Given this list of marker genes XYLB, NOB1, FXYD5, ZIC3, PUS1, MAFG, RASSF3, HSF2BP (NCBI Gene Id 11077), RNASEK, GBP2, NOP10, LCP1, RPL31, BCKDHB, OSTF1, RPL15, FOXO1, TPST2, POLDIP2, PRDX3, ARHGAP25, SPMIP10, CCR4, NME2 (NME/NM23 nucleoside diphosphate kinase 2), MRPL46, PSMG1, IGFBP1, CCHCR1, EIF3H, PDE3B (NCBI Gene Id 5140), GIPC1, CRLF2, C19orf12, STT3B (NCBI Gene Id 201595), CYTH4, PCCA, RPL10, IPCEF1, MRPS18B, ING5, IKZF2, MRPL23, SMAP2, NICN1, ALAS1, SELENOS, DYRK2, RPS26, AFDN, MFNG, CYP20A1, GIMAP3P, COPS9, PPP1R7, BRI3BP, RPL12, LGMN, TECR, IL10RB, ADGRB1, XPOT, ALDOA, NOL12, MRPS9, HADH, HIGD2A, TMEM25, EEF1D, ITM2B, BAIAP3, COQ2, EIF3E, ABHD14A, SNAP47 (NCBI Gene Id 116841), FBXO31, ATP5MJ (NCBI Gene Id 9556), PSMB3, EIF4B, B2M, STING1, MMP3, TH, DHRS1, MTAP, MYO1G, HEXB, PIGX, WDR59, IL7R, SRPX, MRRF, FBXL8, RFC2, PSMB1, OXCT1, GPR65, NXPH1, N4BP2L1, SHISA5, MTURN, TRMT1, PYHIN1, ALDH2, RAPGEF4, ZFP36L1, IPO4, S100A10, TTC9B, PSMA7, CD226, PRKAA1, TNFAIP8L2, VAMP8, CCNG1, GID4, TAGLN2, GSTP1, CLIC1, COMMD5, ISCA2, MLEC, SUCLG2, CD7, SLFN5, COX7A2L, PSME2, LTB, IFT22, ISYNA1, NPC2, EYA2, IL12RB2, MRPL48, RPL29, SNX5, MFGE8, NUP210L, PSMB9, POLR2F, SLC25A5, DDX51, TMEM185A, LEPROTL1, MED11, SBSN, PCBD2, ANKRD13B, TBC1D32, CNPPD1, RAC3, SMAD1, LY9, RIPPLY3, ASCL4, C19orf38, IFI35, KCNA2, ATP1B3, OSM, GLRX5, POLRMT, CELA1, CTPS2, PVT1, RRP15, FUT11 (fucosyltransferase 11), UTRN, CD53, RPS6KA1, AGFG1, here is a description of the gene set: BACKGROUND: Dendritic cells (DC) play a central role in primary immune responses and become potent stimulators of the adaptive immune response after undergoing the critical process of maturation. Understanding the dynamics of DC maturation would provide key insights into this important process. Time course microarray experiments can provide unique insights into DC maturation dynamics. Replicate experiments are necessary to address the issues of experimental and biological variability. Statistical methods and averaging are often used to identify significant signals. Here a novel strategy for filtering of replicate time course microarray data, which identifies consistent signals between the replicates, is presented and applied to a DC time course microarray experiment. RESULTS: The temporal dynamics of DC maturation were studied by stimulating DC with poly(I:C) and following gene expression at 5 time points from 1 to 24 hours. The novel filtering strategy uses standard statistical and fold change techniques, along with the consistency of replicate temporal profiles, to identify those differentially expressed genes that were consistent in two biological replicate experiments. To address the issue of cluster reproducibility a consensus clustering method, which identifies clusters of genes whose expression varies consistently between replicates, was also developed and applied. Analysis of the resulting clusters revealed many known and novel characteristics of DC maturation, such as the up-regulation of specific immune response pathways. Intriguingly, more genes were down-regulated than up-regulated. Results identify a more comprehensive program of down-regulation, including many genes involved in protein synthesis, metabolism, and housekeeping needed for maintenance of cellular integrity and metabolism. CONCLUSIONS: The new filtering strategy emphasizes the importance of consistent and reproducible results when analyzing microarray data and utilizes consistency between replicate experiments as a criterion in both feature selection and clustering, without averaging or otherwise combining replicate data. Observation of a significant down-regulation program during DC maturation indicates that DC are preparing for cell death and provides a path to better understand the process. This new filtering strategy can be adapted for use in analyzing other large-scale time course data sets with replicates. from publication Olex AL, Hiltbold EM, Leng X, Fetrow JS (PMID 20682054) studied in species Homo sapiens Genes down-regulated in bone marrow-derived dendritic cellstreated by poly(IC): 1h versus 24h. Human Gene Set: GSE21033_1H_VS_24H_POLYIC_STIM_DC_DN